The following is a description of a gene set: Mouse Gene Set: GOMF_COA_TRANSFERASE_ACTIVITY Catalysis of the transfer of a coenzyme A (CoA) group from one compound (donor) to another (acceptor). species: Mus musculus, and this is the list of marker genes: Acaa1a, Acaa1b, Oxct2a, Oxct2b, Acsm3, Sugct, Oxct1